Given this list of marker genes BGLAP, PRKN, SYT1, MICU3, STX1B, NLGN1, PPP3CA, CACNA1B, SNCA, STXBP1, GPR158, SLC4A8, SLC17A8, DRD4, KMO, GPER1, STX1A, DRD2, ITGB1, RAB3B, RAB3GAP1, DTNBP1, SLC18A3, BAIAP3, TACR2, ADORA2A, here is a description of the gene set: species: Homo sapiens Human Gene Set: GOBP_POSITIVE_REGULATION_OF_NEUROTRANSMITTER_TRANSPORT Any process that activates or increases the frequency, rate or extent of the directed movement of a neurotransmitter into, out of or within a cell, or between cells, by means of some agent such as a transporter or pore.